The following is a description of a gene set: Any process that stops, prevents, or reduces the frequency, rate or extent of mRNA processing. Human Gene Set: GOBP_NEGATIVE_REGULATION_OF_MRNA_PROCESSING species: Homo sapiens, and this is the list of marker genes: BARD1, SRSF12, SAP18, SRSF4, SRSF9, RBMX, PCBP4, C1QBP, SRSF10, SFSWAP, RBM10, SRSF6, ACIN1, NPM1, CELF4, RNPS1, RBM20, SRSF7 (NCBI Gene Id 87459), U2AF2, HNRNPK, RBM42, PTBP1, DYRK1A